The following is a description of a gene set: ATP-binding cassette sub-family G member 8 (ABCG8 aka sterolin-2), is a "half transporter", that forms a complex with another half transporter ABCG5 in the endoplasmic reticulum. This complex translocates to the plasma membrane to mediate the ATP-dependent intestinal absorption and facilitation of biliary secretion of cholesterol and phytosterols (eg sitosterol). Defects in either of these half transporters result in loss of enterocyte discrimination between cholesterol and sitosterol causing sterol accumulation and predisposition for atherosclerosis. Defects in ABCG8 are the cause of gallbladder disease 4 (GBD4; MIM:611465), one of the major digestive diseases. Gallstones are composed of cholesterol (cholelithiasis) and are the common manifestations of GBD in western countries. Defects in ABCG8 also cause sitosterolemia (MIM:210250), characterised by unrestricted intestinal absorption of both cholesterol and plant-derived sterols causing hypercholesterolemia and premature coronary atherosclerosis. Patients with sitosterolemia absorb between 15 and 60% of ingested sitosterol, and they excrete only a fraction into the bile. Reactome Pathway: Defective ABCG8 causes GBD4 and sitosterolemia part of: ABC transporter disorders species: Homo sapiens, and this is the list of marker genes: ABCG8, ABCG5